Given this list of marker genes mt-Tl2, Fundc1 (NCBI Gene Id 72018), Abraxas2, Gm12258, Oacyl, Map1b, Gm9905, Mdm4, Myo10, Dock3, Lars1, Ndrg1, Ccp110, Gm13470, Mir6985, Bach2os, D130017N08Rik, Tada2a, Tyw1, Zfp365, Foxp1, Ankrd1, Gm15524 (NCBI Gene Id 102631986), Itih2, Snd1, Casp4, Pwwp2a, Tns1, Cd276, Pard3, Apmap, Csde1, Zfhx4, Cflar, Aars1, Cald1, Ahcyl1, Gm4430, Prdm15, Ubr4, H3c13, Gm10475, Hal, Ing4, Ubp1, Slco1a5, Atp5mc3, Mannr, Rny1, Rad21, Grhl1, Mycl, Ptbp1, Atf6, Hsp90aa1, A230072C01Rik, Zcchc2, Kcnk2, Aldh18a1, 4930573C15Rik, Rab39b, Mir3473f, Supt7l, Runx2os2, Smim10l1, Trim24, Spen, Rasal2, Ep400, Zc3h18, Snx33, Alkbh3os1, Igsf5 (NCBI Gene Id 72058), Ywhag, Zbtb18, Naaa, Plekha4, Sh3tc2, Tpx2, Gm15564, Ddit3, Gm6410, Tcte2, Cryz, Spata1, Arl6ip5, Nol12, mt-Th, Snai2, 5930430L01Rik, Marchf6, Eps8 (epidermal growth factor receptor pathway substrate 8), Zfp938, Tenm4, H4c14, Pgk1, Ncl, Btf3l4, Gm34767, 4930555B11Rik, a, Ciart, Eya3, Amz1, Zfp598, Thsd7a, Pnpt1, Slc41a3, Pacsin2, Denr, Tnfsf8, Tmem231, Kctd10, 2810430I11Rik, Prkg2, Ascc3, Plekha1, Tnpo3, Plekhm1, Ywhaz, 3110099E03Rik, Pycr1, 9330136K24Rik, Lmbrd1, Cers2, Kifc5b, Plscr2, Gpat3, Gm15559, Fibcd1, Usp6nl, Gpatch3, Ppp1r15b, Il23a, Sf1, Lrrk1, H1f10, Ppp1r15a, Ostn (osteocrin), Morc3, Amacr, Gm15417 (predicted gene 15417), Ndfip2, Ralgapb, Mideas, Soat2, Hdac8, U90926, Hspa9, Mrps21, Lime1, Pnrc2, Bpifc, Tmem248, 2700069I18Rik, Med24, Kdm6b (NCBI Gene Id 216850), Gm25388, Rcc2, Dst, Taf5, Wdfy1, Gtpbp4, Prkd2, Mir707, Rnf11, Mad1l1, Wdr25, Ank1, Ttc27, 6030452D12Rik, Gm12602, 8430423G03Rik, Itgb5, Ppp2r5a, Abraxas1, Furin, Uxt, Gm29257, Trim66, Angpt1, Parl, Gpx4, Edem3, Zfp945, Ptpn21, Idh3b, Iars1, Erlin1, Necap2, 1700018L02Rik, Zgpat, Islr2, 6430548M08Rik, Slc25a39, Fcgr2b, Loxl1, Trim46, Atf3, Cr1l, Sdcbp, Psen2, Lkaaear1, Aldh1l2, Kyat1, Mapk8ip2, Cmss1, C130036L24Rik, Eif2s2, Mdfic, Zbed3, Trbv27, Rpl9-ps8, Cog5, Slc4a1ap, Rbm39, Stk40, Nfatc1, Acd, 1700055D18Rik, Fars2, Chac1, Ss18l2, Plekhb1, Pxk, Nfe2l1, Camkv, Gtpbp2, Lcn2, Rpl7, Vldlr, Kmo, Dusp6, Cilk1, Nrip2, Gpr85, Mt2, Usp43, Gm12273, A530013C23Rik, Ugt1a6a, 4930417H01Rik, Pxdn, Gm25408, mt-Nd5, Acaa1a, Gm9929, Gm14472, Tmtc2, Mrpl24, Nupr1, Cebpg, Mrpl44, Pex11g, Tmem135, Med23, Scarb1, Ulk2, Mir1932, Cdk12, Pigk, Fem1c, Toporsl, Rpa3, Trp53inp2, Znhit3, Snf8, Cox18, Actr3, B9d2, Zyx (zyxin), Hmx3, Ubald2, Aff1, Rpl13a, Marcksl1-ps4, Mir99ahg, Bbof1, Kctd15, Otud7b, Lyrm1 (LYR motif containing 1), Zbtb38, Coasy, Got1, Arid5a, Commd1, A930007I19Rik, Snx1, 2210408F21Rik, Gm5464, Sspo, Tbce, Trappc10, Tgif1, Ccdc7b, Lrrc14, Pnkp, Gsk3a, Cdk5rap2, Gm36401, Gdf9, Atg10, Mir6948, Slc4a11, Zfp623, Slc7a11, Zfp184, Pibf1, Acad8, Pard6a, Dnaaf10, Bend6, mt-Ts2 (mitochondrially encoded tRNA serine 2), Ube2r2, Gm35066, Brinp1, Acot2, Tnfaip2, Peds1, Ubr2, Phyhd1, Cnpy2, Trib3, Slc19a2, Slfn5os, Ppp4r1, Tyw3, Gckr, Thap6, Gzf1, Cav1, Dnaja3, Gm23698, Slc20a1, Acbd3, Akr1b1, Mmp19, Map7d1, Prss12, Sbds, 1700025O08Rik, Rgs12, Ngef, Smurf1, Sh2d6, Gm8357, Mars1 (methionine-tRNA synthetase 1), BB557941, Tbc1d17, Pno1, Ciao2a, Akt1s1, Map3k20, A630023A22Rik, Zfp128, A330009N23Rik, Clcn3, Rpl35, Sertad2, Dcun1d3, Uqcrq, Nars1, Slc25a29, Zfp35 (zinc finger protein 35), Btg1, Zfp729a, Eif4g2, Incenp, Bcl9, Igfbp4, Slc16a14, Txndc12, Taf15, Elmo1, Wars1, Arl14ep, Manea, Umad1, Ndufaf1, Kazald1, Spag5, Pck2, Surf6, Fibin, Cdc42bpa, Arhgef40, Arhgef2, Ddr2, Slc37a3, Cd74, Nrip1 (nuclear receptor interacting protein 1), here is a description of the gene set: Genes containing one or more binding sites for (Ddit3) in their promoter regions (TSS -1000,+100 bp) as identified by GTRD version 20.06 ChIP-seq harmonization. Mouse Gene Set: DDIT3_TARGET_GENES studied in species Mus musculus from publication Yevshin I, Sharipov R, Kolmykov S, Kondrakhin Y, Kolpakov F (PMID 30445619)